Given this list of marker genes KLHL7-DT, RNF216P1, RNU5B-1, NOP2, NDUFB9, C2orf42, RPL24, SNX16, ZBTB9, CCDC43, KIAA1671 (KIAA1671), KLHL32, POLG, PFKM, ITFG2-AS1, EMP1, BCAR3, PAMR1, TFIP11, MT-TT, MED15, MT-ATP6, MTF2, ANG, RNU12, MT-ATP8, SYNGAP1-AS1, KNL1, RNVU1-6, MT-TS1, MT-TI, MT-TP, PLCH1, ILF2, RNU2-2P, RNVU1-29, CCDC107, RPL5, TMEM39A, TFIP11-DT, COQ6, GADD45A, EIF3B, DUSP19, HCG14, FRG1HP, MED16, WDR74, RNU4-2, MT-TE, MT-TK, STRAP, HBB, LRP6, C9orf72, NCOA7, NAGK, KLHL7 (kelch like family member 7), SNORD118, H4C5, NDUFS7, TATDN1, MT-ND6, SP2, LINC01719, RN7SKP264, FCHSD2, POLDIP3, HNRNPH3, SCARNA2, NAA25, H4C2, MYO18B, TIA1, ITFG2, YARS2, RNASE4, NBPF1, MT-TM, MT-RNR1, TMEM259, SCD, MT-ND2, SNORD3A, HSPA6, MT-TF, MGA, POLG-DT, MTCO3P12, RNU5E-1, here is a description of the gene set: from publication Yevshin I, Sharipov R, Kolmykov S, Kondrakhin Y, Kolpakov F (PMID 30445619) studied in species Homo sapiens Genes containing one or more binding sites for (DICER1) in their promoter regions (TSS -1000,+100 bp) as identified by GTRD version 20.06 ChIP-seq harmonization. Human Gene Set: DICER1_TARGET_GENES